Given this list of marker genes KRT17, DVL3, FZD2, WNT5A, KRT6A, COL7A1, DVL1, KRT6B (NCBI Gene Id 3893), KRT16, here is a description of the gene set: Onychogryphosis of fingernail species: Homo sapiens Thickened fingernails. Human Gene Set: HP_ONYCHOGRYPHOSIS_OF_FINGERNAIL